The following is a description of a gene set: Human Gene Set: GOBP_PIGMENT_METABOLIC_PROCESS The chemical reactions and pathways involving pigment, any general or particular coloring matter in living organisms, e.g. melanin. species: Homo sapiens, and this is the list of marker genes: UGT1A1, APPL1, WNT5A, COX15, DCT, SLC25A38, ATP5IF1, TMEM14B, RPE65, ALAD, UGT1A4, PGRMC1, CTNS, IREB2, HMBS, HMOX2, OCA2, AMBP, TMEM14C, SLC25A39 (NCBI Gene Id 51629), TSPO, FECH, TYRP1, TMEM14A (transmembrane protein 14A), UGT1A7, BLVRB, HMOX1 (heme oxygenase 1), DDT, SLC6A9, ABCB6, CDH3, UGT1A9, BLVRA, ZEB2, LCT, SLC48A1, SLCO1B1, MFSD12, ABCB7, GIPC1, SLC24A5, SLC7A11, SLCO1B3, PMEL, IBA57, ASIP, ALAS2, HPX, UROS, ABCC2, TYR, FXN, FLVCR1, UROD, CPOX, SRRD, ABCB10, TMEM14DP, BDH2, ATP7A, TRPC1, CITED1, OPN3, ALAS1, PPOX, SLCO2B1, UGT1A8 (NCBI Gene Id 54576), SLC45A2, BCL2, SLC46A1, GPR143, COX10, RAB38, SLC11A2, TBX2, UGT1A10, MC1R, ABCC1, TMEM14EP, NFE2L1, RAPGEF2